The following is a description of a gene set: The directed movement a dense core granule within a cell. species: Mus musculus Mouse Gene Set: GOBP_DENSE_CORE_GRANULE_TRANSPORT, and this is the list of marker genes: Kif1a, Mapk8, Kif5b, Sybu, Kif5a, Trim46, Kif1c, Ppfia2, Syt4, Tanc2, Map2, Eipr1, Mecp2, Kif1b